Given this list of marker genes SLC7A9, CFI, GAN, SLC26A1, VWA7, ZNF148, P2RX5, OR2W1, JPT2 (Jupiter microtubule associated homolog 2), HNF1B, ZFPM2, KLHDC7A (NCBI Gene Id 127707), CES5A, HNF4A, HOXD4, TTLL6 (tubulin tyrosine ligase like 6), ARHGAP24, LINC00671, CS, HAO1, CYP2E1, STAT5B, MYL2, PAQR9, BCL11A (BCL11 transcription factor A), COL9A1, TLCD1, FLRT1, SERPINA7 (serpin family A member 7), HESX1, SLC4A4, SHKBP1, PPP2R5C, ARL4C, TNS1, PKHD1, ASB4, MOSMO, C1orf116, PRICKLE1, ISL1, LYSMD2, APCS, HEPACAM2, SLC5A2, ZFHX4, DAB2, APOM, SOSTDC1, CALD1, BDNF, ZNF827, TINAG, ERRFI1, MSH5 (mutS homolog 5), BMI1, EPHA3, DPYD, LECT2, PKP3, PCBP1, NR5A2, AGTR2, TLE4, FAM20C (FAM20C golgi associated secretory pathway kinase), RBM47, KRT26, RNF186, GUCA2B, BPIFA1, MGAM, ERG, CDAN1, HOXA10, CSNK1A1L, SLCO1B1, PDLIM1, PDGFRA, NR2F1 (NCBI Gene Id 7025), THOC5, HOXC6, E2F6, PLA1A, CRB3, NRP1, UGT2A3, RAB3IP (RAB3A interacting protein), AFM, OLFM4, CTAGE4, SLC39A14, CLOCK, ELF4, KLF9, NOL4L (NCBI Gene Id 63890), ZBTB4, BTG4, GPX1, CDH17, HOATZ, CKM, NCKAP5, HTR7, ANKS1B, POLR2A (NCBI Gene Id 5430), SLC5A4, ROBO3, KCNH6, GATA6, ADAMTS6, ATL2, CBFA2T2, PPP2R2B, NRK, ZMYND8, FGFR4, NFIX, CDK2, SUCNR1, LIPC, CUEDC1 (CUE domain containing 1), NECTIN1, ATP2B3, HGFAC, PDZK1IP1, PLG, HPN, SEMA4G, SGK2, SRSF7, PPP1R2B, TM4SF4, RARB (NCBI Gene Id 5915), JADE1, CTTNBP2NL, ANXA13, PBX2, HOXA4, G6PC1, LEAP2, RBFOX1, FOXP2, TM4SF20, SERPINA6, RREB1, SSTR3, RALGPS2, PLA2G4A, MMP11, HABP2, GOLT1A, ALB, WBP4, MAB21L2, SOAT2, TCEA3, SLC5A7, DZIP1L, PTBP1, HOXC4, CA5A, TMEM88, SLC6A5, SEMA3A, SPTSSB, MYO18A, ZNF143, FXYD2, ADAM11, PABPC1, A1CF, LPAL2, TBX2, E2F3, CHRD, EGR1, SFRP4, COL4A5, RORB, GAS2, HOXB9, CDKL5, EFEMP1, LGALS2, NLGN1 (neuroligin 1), SLC5A1, PABPC3, GC, NECAP1, TBXAS1, NR1H4, SLC3A1, MTMR11, USP3, MSX2, AFP, TMED6, DRAM2, SERPINA4, MBNL2, SATB2, ZFHX3 (NCBI Gene Id 463), UGT1A4, MITF, MYRF, IGFBP1, DMD, FOXA2, GEN1, FGA, CARMIL3, HRK, NPAS2, ACVR2A, SLC7A13, EEPD1, CHCHD7, UGT1A1, ANPEP, KIF12, CDH16, SERPINA10, HAVCR1, ADD3, PTH1R, SLC26A3, VSIG1, GLRA2, RBMS1, COLCA1, GUCA2A, PCF11, NFE2L2, RNASE4, LUC7L3, BCL9, CNTD1, ZBTB20, EVA1A, UGT1A6, ZIC2, COL4A6, SOX3, HNF1A, KITLG, KCP, here is a description of the gene set: studied in species Homo sapiens Human Gene Set: HNF1_01 Genes having at least one occurrence of the motif GGTTAATNWTTAMCN in the regions spanning 4 kb centered on their transcription starting sites. This matches the TCF1 transcription factor binding site V$HNF1_01 (v7.4 TRANSFAC).